The following is a description of a gene set: Mouse Gene Set: GOBP_RESPONSE_TO_CORTICOSTERONE studied in species Mus musculus Any process that results in a change in state or activity of a cell or an organism (in terms of movement, secretion, enzyme production, gene expression, etc.) as a result of a corticosterone stimulus. Corticosterone is a 21 carbon steroid hormone of the corticosteroid type, produced in the cortex of the adrenal glands. In many species, corticosterone is the principal glucocorticoid, involved in regulation of fuel metabolism, immune reactions, and stress responses., and this is the list of marker genes: Cdkn1a, Agtr1a (NCBI Gene Id 72294), Aanat, Ucn3, Maob, Th, Comt, Nr3c1, Htr7, Fos, Npas4, Fosb (FBJ osteosarcoma oncogene B), Crh, Nr3c2 (nuclear receptor subfamily 3, group C, member 2), Fosl1, Star, Foxo3, Nefl, Avpr1a, Hdac6, Trh